The following is a description of a gene set: species: Mus musculus This event has been computationally inferred from an event that has been demonstrated in another species.<p>The inference is based on the homology mapping from PANTHER. Briefly, reactions for which all involved PhysicalEntities (in input, output and catalyst) have a mapped orthologue/paralogue (for complexes at least 75% of components must have a mapping) are inferred to the other species. electronically inferred by orthology from the curated human pathway part of: Ketone body metabolism Reactome Pathway: Utilization of Ketone Bodies, and this is the list of marker genes: Oxct1, Oxct2b, Oxct2a, Bdh1